Given this list of marker genes ALG9, here is a description of the gene set: studied in species Homo sapiens Reactome Pathway: Defective ALG9 causes CDG-1l part of: Diseases associated with N-glycosylation of proteins Alpha-1,2-mannosyltransferase ALG9 (ALG9) normally catalyses the transfer of mannose to the lipid-linked oligosaccharide (LLO) precursor. It adds the 7th and 9th mannose moieties to LLO. Defects in ALG9 are associated with congenital disorder of glycosylation 1l (ALG9-CDG, CDG1l; MIM:608776), a multisystem disorder caused by a defect in glycoprotein biosynthesis and characterised by under-glycosylated serum glycoproteins. CDG type 1 diseases result in a wide variety of clinical features, such as defects in the nervous system development, psychomotor retardation, dysmorphic features, hypotonia, coagulation disorders, and immunodeficiency. The LLO profile showed accumulation of (GlcNAc)2 (Man)6 (PP-Dol)1 and (GlcNAc)2 (Man)8 (PP-Dol)1 fragments, suggesting a defect in ALG9 and correlating with the normal function of ALG9 in adding the 7th and 9th mannose moieties.